Given this list of marker genes EP300, IL23A, IHH, NCKAP1L, NFKBIZ, PRKCZ, RIPK2, RUNX1, SOCS5, RUNX3, BRD2, ZBTB16, ZAP70, OPA1, ITPKB, CD80, AP3B1, HLA-DRA, SOCS1, FOXP3, SHB, LILRB4, NFKBID, NKAP, CD86, MALT1, IL23R, ANXA1, IFNG, TNFSF4, NLRP3, BRD4, CCL19, LGALS9 (NCBI Gene Id 90793), PNP, CBFB, IL12RB1, ZBTB7B, SHH, TGFBR2, GLI3, RHOA, KLHL25, IL2RG, IL4R, MIR21, SASH3, RARA, AP3D1, ADA, IL18, HLA-DRB1, GPR65, IL12B, SYK, CD83, HLX, here is a description of the gene set: Any process that activates or increases the frequency, rate or extent of alpha-beta T cell differentiation. Human Gene Set: GOBP_POSITIVE_REGULATION_OF_ALPHA_BETA_T_CELL_DIFFERENTIATION studied in species Homo sapiens